The following is a description of a gene set: Reactome Pathway: Defective C1GALT1C1 causes TNPS Glycoprotein-N-acetylgalactosamine 3-beta-galactosyltransferase 1 (C1GALT1; MIM:610555) mediates the transfer of Galactose (Gal) from UDP-galactose to single O-linked GalNAc residues (Tn antigens) to form Core 1 structures on glycoproteins. C1GALT1 is active when in complex with the molecular chaperone C1GALT1C1 (aka COSMC; MIM:300611) which assists the folding and/or stability of C1GALT1. Defects in C1GALT1C1 causes somatic Tn polyagglutination syndrome (TNPS; MIM:300622), characterised by the polyagglutination of erythrocytes by naturally occurring anti-Tn antibodies following exposure of the Tn antigen on their surface. Defects in C1GALT1C1 render C1GALT1 inactive and results in the accumulation of the incompletely glycosylated Tn antigen. The Tn antigen is tumour-associated, found in a majority of human carcinomas, and is not normally expressed in peripheral tissues or blood cells. C1GALT1 and C1GALT1C1 belong to the CAZy family GT31 (www.cazy.org). species: Homo sapiens part of: Diseases associated with O-glycosylation of proteins, and this is the list of marker genes: MUC3B, MUC5AC (NCBI Gene Id 730855), MUC16, MUC5B, MUCL1, MUC15, MUC17, MUC6, MUC21, MUC3A, MUC7, MUC20, MUC19, MUC4, MUC2, C1GALT1, MUC1, MUC13, MUC12, C1GALT1C1